Given this list of marker genes Drd2, Grm2, Mapt, Dgki, Pirb, Rapgef4, Htr2a, Bdnf, Slc6a1, Il1b, Drd3 (NCBI Gene Id 13490), Cntnap2, Gnal, Fmr1, Cnr2, Prrt1, Adnp, Ptk2b, Adora1, Slc6a4, Pcdh17, Pten, Npy5r, Vps13a, Grid2, Penk, Stxbp1, Gnai2, Arc, Bche, Npy2r, Ager (advanced glycosylation end product-specific receptor), Plk2, Pmch, Srf, Adipoq, Sorcs3, Drd4, Slc24a2, Cd38, Drd5, Gnai1, Atad1, Slc24a1, Adcy8, Tprg1l, Shank3, Grik3, Gabbr1, Tnr, Abhd6, Grid2ip, Sorcs2, Gria1, Htr6, Cbln1, Pla2g6, Ptgs2 (NCBI Gene Id 19225), Mgll, Stau2, Shank2, Htr1b, Ppp1r9a, Arf1, Myo5a, Grik1, Pick1, Drd1, Kcnq4, Prkn, Bcl2l1, Iqsec2, Grik2, Kcnb1, here is a description of the gene set: species: Mus musculus Any process that stops, prevents, or reduces the frequency, rate or extent of synaptic transmission, the process of communication from a neuron to a target (neuron, muscle, or secretory cell) across a synapse. Mouse Gene Set: GOBP_NEGATIVE_REGULATION_OF_SYNAPTIC_TRANSMISSION